The following is a description of a gene set: Genes negatively differentially expressed in cell type: CD8+ T cell upon treatment with cytokine: IL-36α in mouse lymph nodes in vivo. Mouse Gene Set: CUI_T_CELL_CD8_IL36A_RESPONSE_DN from publication Cui A, Huang T, Li S, Ma A, Pérez JL, Sander C, Keskin DB, Wu CJ, Fraenkel E, Hacohen N (PMID 38057668) species: Mus musculus Cytokines mediate cell-cell communication in the immune system and represent important therapeutic targets. A myriad of studies have highlighted their central role in immune function, yet we lack a global view of the cellular responses of each immune cell type to each cytokine. To address this gap, the authors created the Immune Dictionary, a compendium of single-cell transcriptomic profiles of more than 17 immune cell types in response to each of 86 cytokines (>1,400 cytokine-cell type combinations) in mouse lymph nodes in vivo. A cytokine-centric view of the dictionary revealed that most cytokines induce highly cell-type-specific responses. For example, the inflammatory cytokine interleukin-1β induces distinct gene programmes in almost every cell type. A cell-type-centric view of the dictionary identified more than 66 cytokine-driven cellular polarization states across immune cell types, including previously uncharacterized states such as an interleukin-18-induced polyfunctional natural killer cell state., and this is the list of marker genes: Tm6sf1, Adcy7, Sipa1, Cd5, Stk4, Mta3, Thy1, Zdhhc20, Cd37, Kmt2c, Srgn, Ypel3, Itgae, Cox7a2l, Btg2, Stim1, Emp3, Itm2b, Ostf1, Cd48, Cd3e, Tagln2, Ighm, Cd7, Timp2, Dgka, Atp11b, Arhgef18, Chd3, Foxp1, Celf2, Tent5a, Tdrp, Igkc, Neurl3, Smad7, Il7r, Srpk2, S100a13, Setx, Crlf3, Nkg7, Dgkz, Atp1b3, Hsd11b1, Sell, Arhgef1, S1pr1, Rgs10, Atox1, Cd8b1 (CD8 subunit beta 1), Tbc1d10c, Rnf167, Cd2, Arl5c, Itpkb, Cd3d, Rab37, Tspan32 (tetraspanin 32), Selenop, Selplg, Gmfg, Jakmip1, Bcl9l, Mgst2, Add3, Arrb2, Pycard, Ets1, Acp5, Trbc2, Adgre5, Pnrc1, Gpsm3, Septin1, Cd3g, Itgb7, Laptm5, Flna, Hdac7, Rapgef4, Ccr9, Cotl1, Ptpn18, Tcp11l2, Klrd1, Tecpr1, Add1, Evl, Tsc22d3, Ahnak, Dapl1, Zfp36l2, Arhgap15, Myl6, Tmem59, Npc2, Ctsd, S100a10, Smpdl3a, Bin2, Cd55, Pik3ip1, Myh9, Commd8, Pdcd4, Macf1, Arhgap45, Rasgrp2, Hp1bp3, Arhgdib, Tmem108, Mbnl1, Otulinl, Tmem50a, Psap, Gm2a, Gnai2, Epsti1, Ramp1, Ccnd3, Prex1, Ogt, Entrep3, Faah, Actn2, Mxd4, Actn1, H2az2, Plec, Lef1, Saraf, Gimap3, Akap13, Stk38, Tle5, AB124611, Arhgap9, Traf3ip3, Ankrd44, Klf3, Fam78a, Ikbkb, Klf2, Ripor2, Dnajc15 (DnaJ heat shock protein family (Hsp40) member C15), Gtf2i, Cnot6l, Lsp1, Coro1a, Crip1, Ucp2, Dap, Cmah, Cd96, Trbc1, Pold4, Sh3bgrl3, Oxct1, Frmd8, Pitpnc1, Map4k2, Smc4, Prkcb, Limd2, Acap1, Sidt1, Rasgrp1, Kif21b (NCBI Gene Id 320287), Txnip, Macroh2a1, Skap1, Slc12a7, Scp2, Tspo, Bin1, Atp2a3, Fxyd5, Bnip3l, Uqcrh, Hvcn1, Ctsw, Rabac1, Paip2, Fam169b, Ppp1ca, Madd, Hcst, Lck, Ltb, Itga4